The following is a description of a gene set: electronically inferred by orthology from the curated human pathway Reactome Pathway: Chromatin organization species: Mus musculus This event has been computationally inferred from an event that has been demonstrated in another species.<p>The inference is based on the homology mapping from PANTHER. Briefly, reactions for which all involved PhysicalEntities (in input, output and catalyst) have a mapped orthologue/paralogue (for complexes at least 75% of components must have a mapping) are inferred to the other species., and this is the list of marker genes: H2ac8 (NCBI Gene Id 319166), H3c7, Rbbp7, H2bc15, Sap30, H2ac10, H2bc12, H2ac13, H4c1, Dot1l, Suds3, Msl3, Smarca2, H4c12, H3c11, Kmt2b, Kmt5b, Mta2, Phf8, Fam124b, H3c2, Smarcc1, Prdm9, Prdm16, Ezh2, Ncoa1 (nuclear receptor coactivator 1), Kat6b, Smarcc2, H2ac23, Smyd3, H2ac19, Setd7, Kdm2b, H4c6, Mbd2, Kansl2, H2ac7, Kansl1, H3c8, Kat7, Ehmt1, Mbd3l2, Pax3, H4c9, H2ac20, H4c11, H2bc3, H2ac11, Actl6b, H2ac15, H2bc1, H2ac25, Suv39h1, H2bc11, Arid1a, H4c17, Setd1a, Kdm4d, H2ac12, Kdm1a, Kmt5c, Brpf1, Kdm6a, H2ax, Jade3, Ctnnb1, H2ac24, Sumo1, H2bc9, Ash2l, Phf2 (PHD finger protein 2), Smarcd1, H3c4, Phf10, Padi4, Prmt5, Smarca4, Mbd3, Nfkb1, H2az2, Nfkb2, Zfp532, H2ac1, Rps2, H2ac4, H3c1, Ss18l1, Smarcd2, H3c6, Setd6, H4c18, Sap30l, H3c3, Bicral, Chd8, H4c2, Rela, Hcfc1, Brwd1, H4c8, Ing4, Bcl7b, Kdm1b, H2bc13, Kdm7a, Prmt3, H2bc22, Kdm4c, H4c3, Smarcb1, Kdm6b, Arid5b, Brpf3, Brms1, Nr2c2, Msl2, Arid4b, H2bc7, Ss18, Zfp687, H4c4, Pwwp2a, H2ac22, Ccnd1, H2ac6, Rbbp4, H2bc14, H3c15, H2bc8, Mta1, Padi6, Bcl7a (B cell CLL/lymphoma 7A), H3f3a, H2bc27, H3c10, Dpf1, H4c14, Carm1, Phf20, H3c13, Jade2, Cdk4